The following is a description of a gene set: species: Mus musculus Mouse Gene Set: GOBP_PHOSPHOLIPASE_C_ACTIVATING_G_PROTEIN_COUPLED_ACETYLCHOLINE_RECEPTOR_SIGNALING_PATHWAY A phospholipase C-activating G protein-coupled receptor signaling pathway initiated by acetylcholine binding to its receptor on the surface of a target cell, and ending with the regulation of a downstream cellular process, e.g. transcription., and this is the list of marker genes: Stim1, Gna11, Chrm3, Anxa7, Itpr1, Plcb1, Prkcb, Orai1, Gnaq, Trpc1